Given this list of marker genes Ppwd1, Igf1r, Lancl1, Cryab, Gprasp2, Vdac2, Folh1, Psap (NCBI Gene Id 19156), C2cd2l, Tlr2, Gsta13, Clu, Fpr3, Pfdn5, Slc40a1, Ptges2, Pth1r, Hcrtr2, Fpr-rs7, Cmklr1, Gipr, Gss, Anxa5, Mc4r, Msr1, Adcyap1r1, Ghr, Mgst2, Gcdh, Pfdn1, Gltp, Crhbp, Pla2g4a, Cd74, Naa80, Nqo2, Lhcgr, P2rx2, Hnf4a, Ppil1, Gsap, Lepr, Ppia, Itgb2l, Pfdn2, Eci3, Sardh, Dmgdh, Laptm4b, Ldlrad3, Fkbp1a, Ide, Itgb2, Mgst1, Prlhr (prolactin releasing hormone receptor), Hmgcr, Gria3, Cd36, Slc46a1, Vipr1, Npr2, Apoa1, Mthfs, Pirb, Ftcd (NCBI Gene Id 14317), Ptges, Scp2, Fshr, Gsr, Rtn4r (reticulon 4 receptor), Oxtr, Ryr2 (ryanodine receptor 2, cardiac), Tlr6, Pth2r, Dbil5, Npr3, Scarb1 (scavenger receptor class B, member 1), Inhba, Ppig, Srd5a2, Adrb2, Ednrb, Gstm2, Epdr1, Soat1, Acaca, Tlr1, Fpr2, Ppih, Crhr2, Acads, Itm2a, Gstm5, Itm2c, Gsta1, Ghrhr, Dbi, Ppp3r1, Acat1, Gstm6, Fbxo2, Gria2, Cert1, Crhr1, Apba3, Gstm4, Sorl1, Hlcs, Calcr, Ldlr, Gria1, Marco, Npr1, Ppihl, Plekha8, Cd1d2, Clstn1, Gltpd2, Hcrtr1, Apbb2, Clip3, Ramp2, Gstm7, Vbp1, Gstm1, Pank3, Tmem120a, Acadm, Gstm3, Mmachc, Ppie, Rxfp2, Acot7, Trem2, Apba2, Gcgr, Fpr-rs3, Ngfr, Apbb3, Vipr2, Map1lc3b, Ramp1, Dhfr, Pank1, Atp1a3, Grin1, Pltp, Phb2, Acadl (acyl-Coenzyme A dehydrogenase, long-chain), Cln8, Folr1, Lbp, P2rx1, Ager, Ppic, Prnp, Ldlrap1, Izumo1r, Acbd3 (NCBI Gene Id 71493), Fzd4, Srd5a1 (NCBI Gene Id 78925), Galr3, Folr2, Gsta5, Cptp, Nktr, Calcrl, Sctr, Acacb, Mc3r, Cd300lf, Glp1r, Fcgr2b, Slc19a1, Hadha, Hba-a1 (NCBI Gene Id 15122), Tgfb2, Apoe, Mag, Prlr, Pcx, Insr, Hsd17b10 (NCBI Gene Id 15108), Cckbr, Ppib, Ephb2, Il23r, Lrp8, Itga2, Bace1, Fasn, Ppif, Apba1, Soat2, Itm2b, Cst3, Dld, Avpr1a, Fkbp10, Alas2, Acbd5, Ppid, Cmklr2, Ltc4s, Pfdn4, Cd1d1, Eci2, Acbd7, Mtr, Galr2, Gnmt, Fkbp1b, Fzd5, Apbb1, Dlgap3, Fpr-rs4, Mthfsl (5, 10-methenyltetrahydrofolate synthetase-like), Acbd6, Ghsr (NCBI Gene Id 208188), Pik3r1, Nod2 (NCBI Gene Id 338538), Col25a1, Gsta2, Pitpna, Vdac1, Tyms, Pnpla3, Ppp3ca, Tm2d1, Chrna7, Fpr-rs6, Acadvl, Galr1, Uros, Hmgcl, Cckar, Glp2r, Pfdn6, here is a description of the gene set: Mouse Gene Set: GOMF_AMIDE_BINDING species: Mus musculus Binding to an amide, any derivative of an oxoacid in which an acidic hydroxy group has been replaced by an amino or substituted amino group.